Given this list of marker genes SLC30A5, PCSK1, ERO1B, CPE, P4HB, HID1, SLC30A8, PCSK2, YIPF5, here is a description of the gene set: Human Gene Set: GOBP_INSULIN_PROCESSING The formation of mature insulin by proteolysis of the precursor preproinsulin. The signal sequence is first cleaved from preproinsulin to form proinsulin; proinsulin is then cleaved to release the C peptide, leaving the A and B chains of mature insulin linked by disulfide bridges. studied in species Homo sapiens